The following is a description of a gene set: studied in species Homo sapiens Assembly of the cytochrome c (cytochrome bc1) reductase (Complex III) was mainly investigated in yeast. The process in humans is considered to recapitulate the process in the yeast system based on the high similarity in structure and composition of the yeast and human complexes. Human Complex III probably consists of two identical sub-complexes, each containing at least 11 subunits: the catalytic core containing cytochrome b (MT-CYTB), cytochrome c1 (CYC1), and the Rieske protein (UQCRFS1), as well as the additional subunits UQCRC1, UQCRC2, UQCRC10, UQCRC11, UQCRCB, UQCRCH, UQCRCQ. While complex I, III, and IV form a supercomplex, there is no evidence of any physiological advantage of this configuration. Mutations in nuclear genes coding for subunits of Complex III, as well as assembly factors, can cause complex III deficiency (MC3D; reviewed in Fernández-Vizarra & Zeviani, 2015). Reactome Pathway: Complex III assembly part of: Respiratory electron transport, and this is the list of marker genes: UQCC5, UQCRC2, UQCR10, FXN, UQCC3, UQCC1, ISCU, UQCRH, NFS1, LYRM4, HSCB, UQCRC1, TTC19, UQCRB, LYRM7, UQCC6, BCS1L, CYC1, MT-CYB, UQCRQ, UQCR11, LETM1, HSPA9, UQCRHL, UQCC2, UQCRFS1